Given this list of marker genes BRSK2 (BR serine/threonine kinase 2), MAP3K4-AS1, PRX, SLITRK2, COL20A1, METRN, S100B, MAL, KIAA1755 (KIAA1755), PMP2, ANO4, CTXND1, KCNH5, INSC, KCNC2, SLC9A3-OT1, FOXD3, DST, PTPRZ1, C10orf90, ADGRB3, TENM3, GINS3, SORCS1, GRIK3, BCAN, TMPRSS5, MIR3659HG, TENM3-AS1, MAG, L1CAM, PLP1, GFRA3, CPXM2, TMEM132B, LRRTM4, GRB14, TMEM92, MOXD1, B3GAT1, SEMA3B, TSBP1, POU3F1, HMGA2-AS1, MDGA2, CSMD3, CDH19, PMP22, PPP1R1C, DHH, PCSK2, SOX10, KCTD8, GABRA2, STK32A, DPP10, XKR4, ZNF804B, KIRREL3, LINC01505, FSTL5, RDH10, SFRP5, LRRTM1, BMP8B, RAB36, EPHA5, MEGF9, TTYH1, FLRT1, C2orf72, CDH1, LRP1B, FMN2, PLLP, ANO3, PLEKHA4, TAFA5, PRSS27, FRMD5, ITGB8, ADAM23, ALCAM (activated leukocyte cell adhesion molecule), LINC01608, BEND6, OPCML, FAM78B, CDH2, CADM1, GRID2, ASPA (aspartoacylase), MMD2, CNP, SMN2, PLEKHB1, HSPA12A, PARD6B, IGSF9B, CADM4, GRIK2, UGT8, TMEM178B (transmembrane protein 178B), SPMIP5, SOX2, CHST9, TFAP2A (NCBI Gene Id 95131), FLRT3, CHL1, MPZ, ATP10B, NKAIN3, ENSG00000259072, PRIMA1, PPP2R2B, TRPV3, GLDN, KCNH8, here is a description of the gene set: from publication Cao J, O'Day DR, Pliner HA, Kingsley PD, Deng M, Daza RM, Zager MA, Aldinger KA, Blecher-Gonen R, Zhang F, Spielmann M, Palis J, Doherty D, Steemers FJ, Glass IA, Trapnell C, Shendure J (PMID 33184181) Human Gene Set: DESCARTES_FETAL_MUSCLE_SCHWANN_CELLS The gene expression program underlying the specification of human cell types is of fundamental interest. The study authors generated human cell atlases of gene expression and chromatin accessibility in fetal tissues. For gene expression, the study authors applied three-level combinatorial indexing to >110 samples representing 15 organs, ultimately profiling ~4 million single cells. The study authors leveraged the literature and other atlases to identify and annotate hundreds of cell types and subtypes, both within and across tissues. Our analyses focused on organ-specific specializations of broadly distributed cell types (such as blood, endothelial, and epithelial), sites of fetal erythropoiesis (which notably included the adrenal gland), and integration with mouse developmental atlases (such as conserved specification of blood cells). These data represent a rich resource for the exploration of in vivo human gene expression in diverse tissues and cell types. studied in species Homo sapiens Marker genes curated from the annotated cluster as represented in the Descartes Human Gene Expression During Development database.